The following is a description of a gene set: Mouse Gene Set: REACTOME_RIPK1_MEDIATED_REGULATED_NECROSIS studied in species Mus musculus RIPK1-mediated regulated necrosis, and this is the list of marker genes: Hsp90aa1, Birc2, Fas, Ubb, Pdcd6ip, Tnfsf10, Casp8, Ubc, Cflar, Uba52 (ubiquitin A-52 residue ribosomal protein fusion product 1), Birc3, Uba52rt, Prkn, Flot1, Mlkl, Ube2l3, Ripk3, Fadd, Xiap, Rps27a, Tradd, Stub1, Flot2, Fasl, Tnfrsf10b, Peli1, Cdc37, Ogt (O-linked N-acetylglucosamine (GlcNAc) transferase (UDP-N-acetylglucosamine:polypeptide-N-acetylglucosaminyl transferase)), Traf2, Ripk1, Sdcbp, Itch